The following is a description of a gene set: studied in species Homo sapiens Human Gene Set: GOBP_POSITIVE_REGULATION_OF_SIGNALING_RECEPTOR_ACTIVITY Any process that activates or increases the frequency, rate or extent of signaling receptor activity., and this is the list of marker genes: IL24, IL26, IL20, ADAM17, IL10, IL19, NCOA3